Given this list of marker genes MEN1, CDKN1A, ATP1A2, CACNA1A, PLP1, CDKN2B, CDKN1B, CDKN2C, SCN1A, PRRT2, here is a description of the gene set: A decrease in the ability to maintain sustained attention is characterized by reduced alertness. species: Homo sapiens Decreased vigilance Human Gene Set: HP_DECREASED_VIGILANCE